Given this list of marker genes MICB, TGFB1, IL2RA, PTPRC, RIPK2 (receptor interacting serine/threonine kinase 2), SOCS1, CXCL8, MS4A1, IL2, here is a description of the gene set: from publication Panapasa JA, Cox RJ, Mohn KG, Aqrawi LA, Brokstad KA (PMID 26148331) Live attenuated influenza vaccines (LAIV) can prevent influenza illness and death in children. The absence of known correlates of protection induced by LAIV requires human studies of underlying mechanisms of vaccine-induced immunity, to further elucidate the immunological processes occurring. In this study, children scheduled for elective tonsillectomy were enrolled in a clinical trial to evaluate the immune response to LAIV, in order to compare T and B cell gene expression profiles. Twenty-three children (aged 3-17 years) were divided into 4 groups; unvaccinated controls, or vaccinated intranasally with LAIV at days 3-4, 6-7, and 12-15 before tonsillectomy. Total RNA extraction was performed on tonsillar tissue and high RNA quality was assured. The samples were then analyzed using a validated RT2 Profiler PCR Array containing 84 gene-specific primers involved in B and T cell activation, proliferation, differentiation, regulation and polarization. The gene expression after LAIV vaccination was subsequently compared to the controls. We observed that at d 3-4 post vaccination, genes were down-regulated, namely APC, CD3G, FASLG, IL7, CD8A and TLR1. Meanwhile at 6-7 days post vaccination, genes were significantly up-regulated, including RIPK2, TGFB1, MICB, SOCS1, IL2RA, MS4A1, PTPRC, IL2 and IL8. By days 12-15 the genes RIPK2, IL4, IL12B and TLR2 were overexpressed. RIPK2 was upregulated at all 3 time points. Our data suggests an overall proliferation, differentiation and regulation of B and T cells in the tonsils following LAIV, where the majority of genes were up-regulated at days 6-7 and normalized by days 12-15. These findings may provide a first step into defining future biomarkers or correlates of protection after LAIV immunization. Genes up-regulated in blood 6d/7d vs 0d in children (3-17) after exposure to Fluenz (LAIV), time point 6D and 7D combined (identical signature), administered i.n. species: Homo sapiens Human Gene Set: PANAPASA_BLOOD_FLUENZ_AGE_03_17YO_6DY_7DY_UP